The following is a description of a gene set: from publication Cui A, Huang T, Li S, Ma A, Pérez JL, Sander C, Keskin DB, Wu CJ, Fraenkel E, Hacohen N (PMID 38057668) Cytokines mediate cell-cell communication in the immune system and represent important therapeutic targets. A myriad of studies have highlighted their central role in immune function, yet we lack a global view of the cellular responses of each immune cell type to each cytokine. To address this gap, the authors created the Immune Dictionary, a compendium of single-cell transcriptomic profiles of more than 17 immune cell types in response to each of 86 cytokines (>1,400 cytokine-cell type combinations) in mouse lymph nodes in vivo. A cytokine-centric view of the dictionary revealed that most cytokines induce highly cell-type-specific responses. For example, the inflammatory cytokine interleukin-1β induces distinct gene programmes in almost every cell type. A cell-type-centric view of the dictionary identified more than 66 cytokine-driven cellular polarization states across immune cell types, including previously uncharacterized states such as an interleukin-18-induced polyfunctional natural killer cell state. Genes positively differentially expressed in cell type: cDC1 (conventional dendritic cell type 1) upon treatment with cytokine: TSLP in mouse lymph nodes in vivo. species: Mus musculus Mouse Gene Set: CUI_CDC1_TSLP_RESPONSE_UP, and this is the list of marker genes: Ahr, Sharpin, Cxcl16, Serpina3g, Cxcl9 (NCBI Gene Id 17329), Apol7c, Cd8a, Ttc39a, Cd207